Given this list of marker genes Phox2b, Zc4h2, Ascl1, Insm1, Rnf220, here is a description of the gene set: Mouse Gene Set: GOBP_NORADRENERGIC_NEURON_DEVELOPMENT species: Mus musculus The process whose specific outcome is the progression of a noradrenergic neuron over time, from initial commitment of the cell to a specific fate, to the fully functional differentiated cell.